Given this list of marker genes ATP6V0A2, TPR, CHD9, REV3L, RNF14, CPSF4, PCF11, TBCE, TAF5L, SPAST, SNX4, CDYL, PIAS2 (NCBI Gene Id 9063), PPP5C, ZBTB22, INPP5E, SEC23IP, PSMF1, TTI1, GPATCH8, MFN1, NFYB, FAM91A1, ATRX, TTLL5, STXBP3, POP4, RSU1, NUBP1, TMEM11, PPP1R3D, UBE4B, BRCA1, NKRF, KLHDC10, MSH3, PIGF, CDK8, CLPX, OSR1, FANCI, TBPL1, TAF2, NMT1, PDXDC1, JRK, EP400, CHD3, SSR1, CETN3, IGBP1, NFATC2IP, SCAMP1, PAXIP1, DIMT1, OARD1, FRYL, ZNF500 (zinc finger protein 500), here is a description of the gene set: Neighborhood of REV3L REV3-like, catalytic subunit of DNA polymerase zeta (yeast) in the MORF expression compendium Human Gene Set: MORF_REV3L species: Homo sapiens Neighborhood of REV3L